Given this list of marker genes TIMP2, CSF3, CXCL6, MMP2, CXCL13, VEGFD, FGF2, here is a description of the gene set: from publication Ju Z, Jiang H, Jaworski M, Rathinam C, Gompf A, Klein C, Trumpp A, Rudolph KL (PMID 17486088) Cell-intrinsic checkpoints limit the proliferative capacity of primary cells in response to telomere dysfunction. It is not known, however, whether telomere dysfunction contributes to cell-extrinsic alterations that impair stem cell function and organ homeostasis. Here we show that telomere dysfunction provokes defects of the hematopoietic environment that impair B lymphopoiesis but increase myeloid proliferation in aging telomerase knockout (Terc(-/-)) mice. Moreover, the dysfunctional environment limited the engraftment of transplanted wild-type hematopoietic stem cells (HSCs). Dysfunction of the hematopoietic environment was age dependent and correlated with progressive telomere shortening in bone marrow stromal cells. Telomere dysfunction impaired mesenchymal progenitor cell function, reduced the capacity of bone marrow stromal cells to maintain functional HSCs, and increased the expression of various cytokines, including granulocyte colony-stimulating factor (G-CSF), in the plasma of aging mice. Administration of G-CSF to wild-type mice mimicked some of the defects seen in aging Terc(-/-) mice, including impairment of B lymphopoiesis and HSC engraftment. Conversely, inhibition of G-CSF improved HSC engraftment in aged Terc(-/-) mice. Taken together, these results show that telomere dysfunction induces alterations of the environment that can have implications for organismal aging and cell transplantation therapies. Human Gene Set: JU_AGING_TERC_TARGETS_UP studied in species Mus musculus Cytokines, growth factors, and secreted proteins that show increased expression on a protein array of samples from aged TERC knockout mice.